Given this list of marker genes NARS2, SLC25A15, NAGS, NR3C1, CLCN2, SARS2, KCNJ10, HLA-B, SCNN1A, CACNA1D, AIP, SCNN1G, HSD11B2 (NCBI Gene Id 3291), SLC12A3, SLC12A1, SCNN1B, KCNJ5 (potassium inwardly rectifying channel subfamily J member 5), CPS1 (NCBI Gene Id 1373), KCNJ1, USP8, IKZF1, CLCNKA, SLC26A3, ASS1, CYP17A1, ASL, OTC, BSND, CA5A, CLCNKB, here is a description of the gene set: Depletion of acid or accumulation base in the body fluids. Human Gene Set: HP_ALKALOSIS species: Homo sapiens Alkalosis